The following is a description of a gene set: species: Homo sapiens To obtain insight into the genetic basis of the increase of functional activity of memory B cells over time, we compared the gene expression profiles of day 7 and day 40 NP-specific/IgG1 memory B cells, GC B cells and plasma cells in immunized WT mice and naïve B cells, before and after activation in vitro. from publication Kaji T, Ishige A, Hikida M, Taka J, Hijikata A, Kubo M, Nagashima T, Takahashi Y, Kurosaki T, Okada M, Ohara O, Rajewsky K, Takemori T (PMID 23027924) Genes up-regulated in day 7 memory B cells versus day 7 plasma cells. Human Gene Set: GSE11961_MEMORY_BCELL_DAY7_VS_PLASMA_CELL_DAY7_UP, and this is the list of marker genes: GFRA1, MYL4, ABHD17B, HNF1A, SLC26A3, LRRCC1, CRIP3, NAP1L1, FAM76B, CES1, ATL1, ZNF512, APOBEC1, JCHAIN, IGHM, OCA2, AICDA, SLC25A37, NOL7, OOSP2, RTN4 (NCBI Gene Id 57142), NOXRED1, PLEKHA2, INO80, C14orf180, LRRK2, CSMD1, SLC6A13, IRAK2, LDHD, CSF2RB, TTPAL, CHKA, MOB1B, LRP2, CPSF3, MDH1, PGAP1, CYFIP1, C15orf39, KCTD3, CBLL1, BHLHE41, CHCHD4, EPS8, ST14, USP38, COPG2, P3H2, IRF2, HMGN3, RASSF4, TALDO1, IL9R, ZBTB20, TMEM17, IRGM, CBFA2T2, PANK4, SNX21, PLD4, ACSL1, TBC1D1, REG3A, MTSS1, EDARADD, UTP14A, NR3C1, COQ2, SIPA1, CORO7, HEXB, ERLIN1, VAV3, HAAO, WDFY2, RAB39A, MARVELD2, QTRT1, OGFOD3, FKBP7, PALS2, UTP20 (UTP20 small subunit processome component), SULF2, LACC1, APOE (NCBI Gene Id 99), ZCCHC24, SORCS2, COBLL1, SCARA5, NOTCH2, SSTR4, GPM6A, LRRC75A, DYNLT3, DUS3L, EIF4EBP1, SERPINI1, CISD1, APIP, VCF1, KICS2, ZBTB18 (NCBI Gene Id 10472), TNFRSF13B, EHBP1 (NCBI Gene Id 23301), NAT2, CAMK2D, CNOT2, POLD4, IL12A, RDH12, SCAMP2, CHST12, SLC1A2, OPCML, STARD10, SLFN13, TSGA13, CD2AP, DBP, AGO4, ZFYVE19, GPD2, WLS, IL20, ST3GAL6, TLR3, TIMM10, P2RX4, MYBPC2, SUSD3, MMAA, ZNF710, CAT, SLCO5A1, MTMR4, SFR1, GPN1, DUSP16, BANK1, TRPM5, HPGD, GCA, BASP1 (NCBI Gene Id 10409), FLCN, GNL3, PPP1R3D, TIRAP, CAPN5, FOXO3, MSH3, LYNX1, GPR137B, SPATA7 (NCBI Gene Id 55812), IYD, PRR12, HMGA2, SHTN1, ERP27, SELENBP1, ITPR1, TRIM14, ZFP90, MAST4, WFS1 (wolframin ER transmembrane glycoprotein), LYL1, ARFGAP3, CKAP2L, FH, ZNF438, RUFY3, NNT (NCBI Gene Id 23530), FAM117A, ARID1B, TPST1 (NCBI Gene Id 8460), SNX9, SEMA4B, SOX12, WDFY4, STXBP1, PIP5K1C, PPM1K, AGTPBP1, MYO7A, SYCP1, PRKCD (NCBI Gene Id 5580), PFAS, MARCKSL1, MTRR, ANKLE2, HELZ2, TDRD7, DNAJA3, KCNJ1, HMGCLL1, PTPRJ, BACE2, IRAG2, MFSD12